Given this list of marker genes KCNN4, PPP3CB, P2RX2, RYR2, SESTD1, MIR133A1, AFG3L2, MIR200C, MIR208B, PTK2B, GPER1, TMC2, PPP3CA (NCBI Gene Id 5530), CXCL11, CACNB3, ATG5, PPP3CC, CACNB4, CD19, CAMK2D, DMD, PLN, PLA2G1B, P2RX5, BAX, P2RX3, GSTO1, MIR21, CAV1, SUMO1, GPR35, ABL1, BAK1, UBR3, NPSR1, KCNK16, CHD7, CBARP, CRACR2A, CACNG6, MIR499A, TMC1, JPH4, TOR2A, CAPN3, AKAP5, F2R, NTSR1, TRPC1, PRKCE, HTT, SNCA, SPG7, SRI, CACNB2, CRHR1, PPP3R2, TMEM38A, MCUB, HRC, CEMIP, PDPK1, CXCR3, P2RY6, PDE4B, JPH3, PRKACA, JPH2, TLR9, MS4A1, MIR328, DHRS7C, ATP1A2, CACNG1, RGS9, JPH1, CXCL9, NGF, GRIN1, CACNB1, ANK2, GRM6, METTL21C, TMEM38B, TGFB1, MIR1-1, UBASH3B, CALCA, GNB5, PDE4D, PLCG1, APLNR, F2, NPPA, NIPSNAP2, PIK3CG, EPO, ATP2A1, ITGB3, DIAPH1, STIMATE, STIM1, CASQ2, AHNAK, CACNA1C, CALM2, DRD1, VDAC1, BDKRB1, LACRT, CORO1A, P2RX1, ASPH, NOS1AP, APP, YWHAE, ATP1B1, LIME1, SELENON, CASQ1, STAC, LYN, TRDN, STRIT1, UCP2, HPCA, SLN, BCL2, PRKD1, FKBP1A, CXCL10, GSTM2, STIM2, REM1 (RRAD and GEM like GTPase 1), SLC8A1, HAP1, AKAP6, P2RX7, FKBP1B, CX3CL1, PSEN2, CACNA1F, PTPN6, TMBIM6, TSPAN13, PPP3R1, CALM1, IL13, CYBA, G6PD, STAC2, MIR93 (microRNA 93), NOS1, UBQLN1, ADCYAP1R1, TRPC3, VMP1, MIR208A, FYN, PML, THY1, CALM3, CLIC2, XCL1, FMR1, P2RX4, PRNP, STAC3 (SH3 and cysteine rich domain 3), CACNA2D1, CD4, BIN1, F2RL3, here is a description of the gene set: studied in species Homo sapiens Any process that modulates the frequency, rate or extent of calcium ion transmembrane transport. Human Gene Set: GOBP_REGULATION_OF_CALCIUM_ION_TRANSMEMBRANE_TRANSPORT